Given this list of marker genes CD8B, AP1M2, CD4, AP2B1, LCK, HLA-A, CD28, AP1M1, AP2S1, AP1S3, PACS1 (NCBI Gene Id 55690), AP2A1, ATP6V1H, ARF1, AP2A2, AP1S1, AP2M1, AP1B1, B2M, AP1S2, AP1G1, here is a description of the gene set: Human Gene Set: REACTOME_NEF_MEDIATES_DOWN_MODULATION_OF_CELL_SURFACE_RECEPTORS_BY_RECRUITING_THEM_TO_CLATHRIN_ADAPTERS Nef-mediates down modulation of cell surface receptors by recruiting them to clathrin adapters studied in species Homo sapiens